Given this list of marker genes CSRNP3, PCNX1, STAP1, GPR37, RRAGB, SFMBT1, CCDC83, KCNK13, CD96, WNT5A, CREB1, SOCS4, AAK1, GNAI1, DLG1, RAP2C, ITFG1, TCP10L, ATXN1, GABRA1, TPD52, MOSPD2, FPGT, DCP1A, CYP7B1, ADGRG7, RBM4B, PXMP4, IL21R, MGAT4A, ZBTB20, MAGI1, IQCJ-SCHIP1, SORCS3, SLC25A19, SNF8, GTF2A1, EDC4, EIF2A, PPP1CC, NCK1, TCF4, DNAAF4, SCAPER, TMTC2, FMNL3, SPTY2D1, HYOU1, MTMR4, IGF1, SLC23A2, NFATC2, GULP1, ZNFX1, RGS3, NOL4, ECPAS, EPM2A, CLN8, TIAM1-AS1, PSMD5, GET1, KIAA1217, PCK1, TIGAR, SRSF3, AMD1, ITPR3, KDM5B, GTF2F2, SDK1, SPTBN1, HPS3, SGMS1, CTNND1, PNPLA1, PACSIN2, ZEB2, RORA, AAGAB, TRIL, LIMK2, TNRC6B, HNRNPK, ADAMTS6 (ADAM metallopeptidase with thrombospondin type 1 motif 6), LCORL, HIPK3, MED14OS, DNAJC13, HERC1, FAM91A1, TP53I11, ATP5MC2, VEZT, LMBR1, DGKH, PPP3R1, HOXA5, UBE2Q2, DDX46, BAZ2A, C2orf68, LRIG1, ATP2B4, GREM1, SLC39A8, LPAR6, PPID (NCBI Gene Id 5481), SP4, SMS, ALDH6A1, CLEC16A, PHLPP1, ZNF451, TTC7B, USP38, DNAI1, AMOTL1, EGFR, KLHL14, PDCL, ICE1, CRIPT, HDAC9, LATS2, CEP85L, MYLK, SERBP1, MBTD1, IFNA1, TRAF6, MTFR2, SOCS7, UBE2D3, ERCC1, M6PR, MCUR1, MAGOHB, ATF7, NAA30, WDR45B, ITIH5, RABL3, SALL1, AMER1, PPP2R5E, OSBP, EPHA7, SLC24A2, USP9X, NFAT5, MAGEB3, VDAC2, HRNR, ALDH9A1, AMMECR1, BCL11A, BAZ1A, TBC1D12, ACTR6, CNIH1, SUPT20H, RPIA, RNF125, HOXD9, HELLS, TRAPPC8, NBEA, ZNF266, EIF3J, CCDC169, NFIA, SAMD13, C1S, ATOSA, PRKACB, MDGA2, CT55, YWHAQ, IRS1, SLC7A11, MAP9, STIM2, here is a description of the gene set: Genes predicted to be targets of miRBase v22 microRNA hsa-miR-12120 in miRDB v6.0 with MirTarget v4 prediction scores > 80 (high confidence targets). Human Gene Set: MIR12120 from publication Chen Y, Wang X (PMID 31504780) studied in species Homo sapiens